The following is a description of a gene set: Genes up-regulated in hypertrophic hearts (due to expression of constitutively active form of PPP3CA) and predicted to be targets of miR-133 microRNA. from publication Ikeda S, He A, Kong SW, Lu J, Bejar R, Bodyak N, Lee KH, Ma Q, Kang PM, Golub TR, Pu WT (PMID 19188439) species: Mus musculus Calcium signaling is a central regulator of cardiomyocyte growth and function. Calmodulin is a critical mediator of calcium signals. Because the amount of calmodulin within cardiomyocytes is limiting, the precise control of calmodulin expression is important for the regulation of calcium signaling. In this study, we show for the first time that calmodulin levels are regulated posttranscriptionally in heart failure. The cardiomyocyte-restricted microRNA miR-1 inhibited the translation of calmodulin-encoding mRNAs via highly conserved target sites within their 3' untranslated regions. In keeping with its effect on calmodulin expression, miR-1 downregulated calcium-calmodulin signaling through calcineurin to NFAT. miR-1 also negatively regulated the expression of Mef2a and Gata4, key transcription factors that mediate calcium-dependent changes in gene expression. Consistent with the downregulation of these hypertrophy-associated genes, miR-1 attenuated cardiomyocyte hypertrophy in cultured neonatal rat cardiomyocytes and in the intact adult heart. Our data indicate that miR-1 regulates cardiomyocyte growth responses by negatively regulating the calcium signaling components calmodulin, Mef2a, and Gata4. Mouse Gene Set: IKEDA_MIR133_TARGETS_UP, and this is the list of marker genes: Usp32, Gnai3, Raph1, Elavl1, Appbp2, Actr3, Ywhaq, Cyld, Sec61b, Mafk, Ptpro, Lhfpl6, Rbpj, Rabgap1, Ankrd12, Slc6a6, Myh9, Arpc5, Ncoa6, Eif4g3 (eukaryotic translation initiation factor 4 gamma, 3), Slc23a2, Cdc42, Sgpp1, Pitpnb, Gpc6, Maml1, Ctbp2, Rbmx, Snx1, Fmnl2, Ebf2, Ppp1r12a, Dnajb6, Ptprd (protein tyrosine phosphatase receptor type D), Nfat5, Ndrg1, Ddx3x, Asph, Akap9, Hif1a, Hs2st1, Sacm1l, Ppp2ca, Rap2c